The following is a description of a gene set: The phosphorylated type 1 insulin-like growth factor receptor phosphorylates IRS1, IRS2, IRS4 and possibly other IRS/DOK family members. The phosphorylated IRS proteins serve as scaffolds that bind the effector molecules PI3K and GRB2:SOS. PI3K then activates PKB (AKT) signaling while GRB2:SOS activates RAS-RAF-MAPK signaling. part of: IGF1R signaling cascade studied in species Homo sapiens Reactome Pathway: IRS-related events triggered by IGF1R, and this is the list of marker genes: GAB1, FGF18, IRS4, NRAS (NCBI Gene Id 4893), IRS1, PIK3C3, PIK3CB (NCBI Gene Id 5291), FGFR2, FGF2, PIK3CA, FGF23, IGF1R, FGF16, PDPK1, FGF22, SOS1 (NCBI Gene Id 7838), TLR9, IGF1, FGF17, FGF7, FGF6, FGF8 (fibroblast growth factor 8), IRS2, FLT3LG, PIK3R4, FGF4, TRIB3 (tribbles pseudokinase 3), FGFR4, KLB, FRS2, FGF10, FGFR1, FGF19, FLT3, THEM4, FGFR3, KRAS, IGF2, AKT2, PDE3B, GAB2, GRB2, FGF20, PIK3R1, FGF5, HRAS, PTPN11, PIK3R2, FGF9, FGF1, KL, FGF3